The following is a description of a gene set: species: Mus musculus Mouse Gene Set: GOBP_NEGATIVE_REGULATION_OF_CANONICAL_WNT_SIGNALING_PATHWAY Any process that decreases the rate, frequency, or extent of the Wnt signaling pathway through beta-catenin, the series of molecular signals initiated by binding of a Wnt protein to a frizzled family receptor on the surface of the target cell, followed by propagation of the signal via beta-catenin, and ending with a change in transcription of target genes., and this is the list of marker genes: Asb15, Tnn (tenascin N), Fzd6, Shisa3, Fuz, Apc2, Cyld, Ccdc88c, Mcc, Lzts2, Emd, Sox10, Sostdc1, Kremen1, Ctnnbip1, Lats1, Dkkl1, Snai2, Sdhaf2, Pfdn5, Sost, Dkk2, Sfrp1, Jade1, Tmem64, Apc, Fzd1, Ankrd6, Wwtr1, Nppa, Rbms3, Frzb, Gsk3a, Tbx18, Stk4, Gsk3b, Mapk14, Gli3, Tpbg, Sox13, Fermt1, Tmem88, Mllt3, Tle4, Amer2, Ctnnd1, Chd8, Ptpru, Ptpro, Foxo1, Sox2, Hdac2, Notch1, Dab2, Dact1, Cdh2, Ruvbl2, Tle3, Tle1, Hdac1, Ctnnb1, Nkd2, Dkk1, Tpbgl, Mesp1, Dkk4, Frmd8, Draxin, Wnt11, Sfrp4, Foxo3, Tmem88b, Mad2l2, Rapgef1, Amer1, Ddit3, Bicc1, Sox17, Nherf1, Sfrp5, Nkx2-5, Shisa6, Gpc3, Wnt5b, Bmp2, Limd1, Tle2, Apoe, Asb3, Dkk3, Lmbr1l, Sox9, Stk3, Nog, Nkd1, Csnk1a1 (NCBI Gene Id 93687), Dab2ip, Gsdma3, Tmem131l, Tcf7l2, Nphp3, Znrf3, Cav1, Cdh1, Shh, Dact3, Axin2, Tmem170b, Axin1, Notum, Amfr, Prkn, App, Ror2, Isl1, Cthrc1, Ppp2r3a, Prickle1, Sfrp2, Egr1, G3bp1, Scyl2, Otud5, Lats2, Gli1, Stk11, Grem1, Mdk, Tle6, Wnt5a, Tle5, Tle7, Invs, Ubac2, Lrp4, Nphp4, Siah2, Smad4, Cby1